The following is a description of a gene set: In cytotoxic T cells (CTL), Protein Kinase B /Akt is activated by the T cell antigen receptor (TCR) and the cytokine Interleukin 2 (IL2), in part by phosophorylation of Akt by Phospholipid dependent kinase 1 (PDK1). The role of PDK1 and Akt in CTL has however not been fully defined. In order to explore the relative roles of these kinases in CTL we used microarrays to profile the gene expression of control and PDK1 null CTL. In separate experiments we compared the gene expression profiles of control and Akt inhibitor treated CTL. from publication Macintyre AN, Finlay D, Preston G, Sinclair LV, Waugh CM, Tamas P, Feijoo C, Okkenhaug K, Cantrell DA (PMID 21295499) Genes down-regulated in cytotoxic T cells: wildtype versus PDK1 knockout. studied in species Homo sapiens Human Gene Set: GSE26290_WT_VS_PDK1_KO_ANTI_CD3_AND_IL2_STIM_CD8_TCELL_DN, and this is the list of marker genes: CTSH, SEC13, CDC37L1, TTC13, RAB5C, GNMT, MCTP1, TCF7L2 (NCBI Gene Id 6934), C8G, COQ10B, ZNF212 (NCBI Gene Id 7988), RASL12 (RAS like family 12), TALDO1, MCCC1, NOL10, ADRB1, SCNN1D, DYNLT3, TMEM115, PAX1, AFG3L2 (NCBI Gene Id 573970), MOB1A, NDUFS3, RIGI, RLIG1 (NCBI Gene Id 91298), AZI2, CERT1, NDUFAF3 (NCBI Gene Id 375340), ZFC3H1, BCKDK, RTL8C, FKBP14, KRT9, BET1 (NCBI Gene Id 10282), C4orf19, ALCAM, PFKFB1, PCK2, ULK1, EIF4EBP2, DENND4B, EIF3I, MGAT4B, HLA-DPB1, DERA, KIT, VNN3P, CASP9, SIK1 (NCBI Gene Id 54018), MAZ, TLX3, RDH14, PIP5K1C, SUCO, RARS1, CNOT1, SLC25A46, TBL3, KLHL4, DHRS7B, BMAL1, COQ4, TSPAN14, WDR46, POLM, SMPD2, ABCD2, SS18L1, PC, TJAP1, CUZD1, LRRFIP2, FBXL12, AFTPH, BFAR, WIPF2, RXRB, SRF, TNIP2, MYC, MED21, DNM2, PRG3 (NCBI Gene Id 10394), CYP4B1, SCRIB, TWF2, SLC39A1, AGL, SFXN3, DVL3, CPB2, MFSD11, DNAJC13, MINDY1, F8, NCBP3, DAXX, GTPBP2, SNX11, POLE3, RSAD1, HDAC5, GFRA3, TMEM184C, ASXL1, MPIG6B, FRG1JP, CRACDL, GALNT11, MEF2C, ACP2, CCT7, PTP4A3, POP7, NANS, RNPEPL1, THOC6, CHM, EBAG9, SFRP5, FAM131A, CIDEB, KLHL36 (kelch like family member 36, NCBI Gene Id 79786), MSN, CRABP2, TIMM13, RNF44, LPXN, CNDP2, BICRAL, ODF2, PSME3, WASF2, NELFCD, CASP4, RAB5B, ARFIP1, LRRC59 (NCBI Gene Id 55379), ZFP37, SEC62, SLC25A42, PLOD1, IKBKG, TRHR, PA2G4, LIG4, SMARCD1, VENTX, TPK1, NDFIP1, KIAA0319L, STK25, SERPINB7, CEBPA (NCBI Gene Id 1050), HHEX, BCCIP, SH2B3, ACOT13, USP6NL, NIPSNAP2, VPS37B, TCF12, TEX13B, CPSF7, ONECUT2, THUMPD2, COL6A2, CELA2A, ASB7, ALDH2, SLC7A7, P2RY6, RAB32, SNHG32, RNF10 (ring finger protein 10), PRDM4, PARN, CYRIB, COPZ1, KAT8 (lysine acetyltransferase 8), RBM38 (RNA binding motif protein 38), AGPAT1, TMEM127, NKRF, TMA7, TNNT2 (NCBI Gene Id 7139), ATP7A, DLST, CCNC, PDPK1, SLC24A2, DDHD2, ICE1, RHOB (ras homolog family member B), GPATCH3, KBTBD4 (kelch repeat and BTB domain containing 4), FBXO2